Given this list of marker genes CLCN3, MAB21L1, PTPN23, CCDC88A, ANKH, VPS41, ASPA, CLP1, GBA1, VPS4A, VPS13D, AMPD2, OPN1MW, PIGA, CNGB3, PDE6C, ATF6, TEFM, PDE6H, OFD1, RPGR, GNAT2, ASAH1, ITPR1 (inositol 1,4,5-trisphosphate receptor type 1), PET100, CNGA3, RNF13, OPN1LW, RANBP2, SLC39A8, DPM1, PIGB, here is a description of the gene set: Any anomaly in the process of ocular fixation, which is the maintaining of the visual gaze on a single location. studied in species Homo sapiens Abnormal visual fixation Human Gene Set: HP_ABNORMAL_VISUAL_FIXATION